Given this list of marker genes UBE3A, NHLRC1, KCNT2 (potassium sodium-activated channel subfamily T member 2), MAPK10, CRELD1, GRIN2A, PCDH19, SCN1A, CLPB, CUX2, DNM1, SCN9A, TRIM8, PAFAH1B1, CACNA1A, GABRA1, OTUD7A, CACNB4, EPM2A (EPM2A glucan phosphatase, laforin), GABRB3, AP2M1, HNRNPU, CHD2, GABRG2, ZEB2, SZT2, SLC32A1, CEP85L, SCN2A, PPP3CA, SCN1B (NCBI Gene Id 6324), FRRS1L, KCNMA1 (NCBI Gene Id 3778), KCNB1, EIF4A2, SRPX2, here is a description of the gene set: Human Gene Set: HP_ATYPICAL_ABSENCE_SEIZURE Atypical absence seizure species: Homo sapiens An atypical absence seizure is a type of generalized non-motor (absence) seizure characterized by interruption of ongoing activities and reduced responsiveness. In comparison to a typical absence seizure, changes in tone may be more pronounced, onset and/or cessation may be less abrupt, and the duration of the ictus and post-ictal recovery may be longer. Although not always available, an EEG often demonstrates slow (<3 Hz), irregular, generalized spike-wave activity.